The following is a description of a gene set: Mouse Gene Set: MIR_448_5P studied in species Mus musculus from publication Chen Y, Wang X (PMID 31504780) Genes predicted to be targets of miRBase v22 microRNA mmu_miR_448_5p in miRDB v6.0 with MirTarget v4 prediction scores > 80 (high confidence targets)., and this is the list of marker genes: Sema3a, Dlx2, Rnf152, Fli1, Pard3b, Nr2f2, Etnk1, Fam78b, Kcnk2, Sfpq, Tmem30a, Kif1b, Hs3st3b1, Bcl10, Psmf1, Magel2, Rfx7, Cntn4, Rbbp5, Mphosph6, Sox6, Zfp1009, Gm14288, Ccdc38, Spred1, Pde1c, Cbln2, Robo1, Slc25a13, St18, Clec12a, Wfdc5, Acp3, Rab40c, Fpgt, Pcdh7, Cep41, Sf3b1, Papolg, Sfrp1, Phyhd1, Slc25a36, Pdgfra, Foxo1, Hnrnpk, Ercc1, 4930513O06Rik, Dbx1, Hrh3, Adam10, Vcan, Dexi, Kctd5 (potassium channel tetramerisation domain containing 5), Rora, Fgf10, Pbrm1 (polybromo 1), Npr3, Zmat3, Kcnd2, Stat5b, Accs, Ucma, Fam107a, Eif5, Fgd6, Bmi1, Fbxo8, Fmn2, Mllt6, Id4